Given this list of marker genes AKT2, RDH13, SCN11A, SLC24A2, SLC24A4, here is a description of the gene set: species: Homo sapiens Any process that results in a change in state or activity of a cell or an organism (in terms of movement, secretion, enzyme production, gene expression, etc.) as a result of a high light intensity stimulus. Human Gene Set: GOBP_RESPONSE_TO_HIGH_LIGHT_INTENSITY